Given this list of marker genes TUBD1, EIF4H, USP20, PPP3CA, MSRB1, CCDC88A, FAM53C, MDFIC, LIPT1, IDO1 (NCBI Gene Id 3620), NOL11, FKBP14, ARFGAP1, MFAP3, IRF1, PKIA, CRKL, PPP1R12B, VRK2, PDE3A, LHFPL2, VPS54, JAG1, TRAK2, TRIB2, PCDH7, TNS3, MEGF9, HPF1, VBP1, BCL6, GET1, CLUAP1, CDC42EP4 (NCBI Gene Id 91740), USP22, SEPHS1, CTNND1, GVINP1, THEM6, GTPBP3, ZNF318, NSD2, TESK2, SLC19A1, ADNP2, KDM1A, FAM114A2, RPP30, IL15, SMARCC1, P2RX7, PAK2, RAB14, U2SURP, POPDC3, TANK, CTRL, RBBP4, WDR37, HCCS, NT5DC2, SETBP1, SLC23A2, PARP2, RPS6KA1, ADGRG6, DYRK4, NELFCD, ZCCHC14, TNFAIP2, TRIB1 (NCBI Gene Id 80272), RNF144A, FAT4, GPATCH3, MTMR4, THAP4, SCRIB, ATG2B, ATP2A2, MTAP (NCBI Gene Id 8008), C1orf174, TBC1D9, SIVA1, PLAAT4, OTUD3, SOCS3, CIRBP, PDGFRA, MFAP1, UBP1, TOP1, CUL3, EIF3B, ACO1, NNMT, SH3BP2, BACH1, NDC1, API5, CDC40, SESN1, YWHAZ, GCLM, PAXIP1, SNN, PDSS1, UNC45A, TTC1, REV1, FAN1, UBE4B, XPO7, TMEM168, MVD, KIF2A, KHSRP, GIGYF2, EXOC1, RBMX, NDST2, ETV1, CTDSP2, ZNF768, KANK1, NCK2, CCT6A, SHMT1, SUSD6, STIP1, UNKL, DRAM1, STX6, SHPK, ATG4B, SCYL3, MPZL1, RBM4, PABPC4, HMG20A, FBXL14, VCPIP1, RCL1, CPED1, MRTFB, RNFT2, MPC2, PINK1, ABCE1, CAND2, KHK, DNAJB1, SF3A1, SSBP3, SLC30A5, RAD1, ZNF330, TNFAIP1, PIAS4, RANBP6, ABCC5, NUP50, SIK2, CASP10, RAB27A, APC, IRF8, ADGRA3 (adhesion G protein-coupled receptor A3), RMND5A, SBNO2, PKP4, JPT2, KIF15, DDX23, SCML1, AMIGO2, REV3L, RGS2, ERLIN1, ORC2, CTSS, KCTD3, ACAA2, SNX13, PIAS2, POLR2B, POLR2H, CXCL9, HMOX2, SFPQ, MRS2, SNRNP27, ANKRD17, CACYBP, AHR, IFI30, RHOBTB3, PFN2, SNRK, UNC119B, here is a description of the gene set: Genes down-regulated in CD4 T cells treated with pioglitazone and over-expressing: FOXP3 and PPARg1 isoform of PPARG versus FOXP3. We identified Pparg as a major orchestrator of the phenotype of adipose-tissue resident regulatory T cells (VAT Tregs). To explore the contribution of Pparg1 and 2 in the generation of the VAT Tregs-specific gene signatures, CD4+FoxP3- T cells were transduced with Foxp3+/- Pparg1 (or Pparg2), treated with Pioglitazone or vehicle, and double sorted for microarray analysis. Human Gene Set: GSE37533_PPARG1_FOXP3_VS_FOXP3_TRANSDUCED_CD4_TCELL_PIOGLITAZONE_TREATED_DN from publication Cipolletta D, Feuerer M, Li A, Kamei N, Lee J, Shoelson SE, Benoist C, Mathis D (PMID 22722857) studied in species Homo sapiens